The following is a description of a gene set: studied in species Mus musculus Mouse Gene Set: chr12F2, and this is the list of marker genes: Ighv1-71, Ighv1-16, Gm9267, Ighv1-24 (NCBI Gene Id 780885), A930023M06Rik, Ighv6-5, Ighv1-69, Mir153, D230030E09Rik, Ighv1-46, Ighv1-57, Ighv10-2, Ighv1-81, Gm18955, Gm19843, Gm25112, Ighv1-84, Gm18441, Ighv8-15, Ighv1-18, Ighv1-17, Ighv1-35, Gm10421, Ighv8-3, Ighv1-85, Ighv1-75, Ighv1-26, Ighv1-37, Gm9238, Ighv1-3, Gm9279, Dnah11, Ighv1-20, Gm6105, Ighv1-42, Gm9227, D430020J02Rik, Zfp386, Ighv1-72, Gm5441, Ighv1-52, Ighv1-31, Gm22170, Ighv1-65, Gm5660, Ighv1-82, Esyt2, Gm9260, Gm6750, Ighv1-13, Ighv1-58, Ighv1-80, Sp4, Ighv1-25, Ighv1-10, Ighv8-16, Ighv8-7, Ighv1-19, Ighv15-2, Gm5034, Ighv1-64, Gm18032, Gm29689, Ighv8-10 (NCBI Gene Id 780957), Ighv1-55, Gm19331, Ighv8-12 (NCBI Gene Id 780960), Gm9251, Abcb5, Ighv1-53, Sp8, Ighv1-62-1, Ighv1-79, Dync2i1, Ighv1-68 (immunoglobulin heavy variable V1-68), Ighv1-86, Ighv8-5, Ighv1-12, Ighv8-4, Ighv1-27, Ighv1-14, Ighv8-11, Ighv1-15, Ighv1-7, Ighv1-47, Ighv1-36, Ighv1-4, Ighv1-29, Ighv1-38, Ighv8-6, Ighv1-62-2, Ighv1-54 (NCBI Gene Id 211331), Ighv1-41, Ighv1-8, Ighv1-28, Ighv6-7, Ighv1-45, Ncapg2, Ighv1-9, Ighv1-50, Ighv1-21, Ighv10-4, Ighv1-83, Ighv10-1, Ighv1-73, Ighv1-74, Cdca7l, Ighv1-70, Gm18340, Ighv1-62, Gm7019, Ighv1-66, Ighv1-76, Gm9245, Vipr2, Ighv1-34, Ighv1-56, Gm17807, Ighv1-60, Ighv8-2, Mir6388, Ighv1-32, Ighv1-21-1, Ighv1-61, Rnu7-ps1, Or5t19-ps1, Ighv1-33, Ighv8-9, Ighv1-39, Ighv1-49, Ighv1-22, Gm9256, Gm6171, Ighv1-51, Ighv1-5, Rpl7a-ps2, Rapgef5, Ighv1-48 (immunoglobulin heavy variable V1-48), Gm18341, Itgb8, Gm18921, Ighv6-6, Ighv1-19-1, Ighv1-44, Ighv1-40, Ncoa4-ps, Ighv1-2, Gm30948, Ighv1-62-3, Gm20658, Ighv1-43, Ighv1-59, Gm9236, Ighv1-78, Gm7142, Ighv1-63, Ighv8-13, Ighv1-6, Ptprn2, Ighv8-14, Ighv10-3, Ighv1-30, Ighv8-8, Gm9280, Ighv1-77, Tmem196, Ighv1-11, Macc1, Ighv1-23, Ighv1-17-1, Ighv1-67